The following is a description of a gene set: Mouse Gene Set: PPARGC1A_TARGET_GENES species: Mus musculus Genes containing one or more binding sites for (Ppargc1a) in their promoter regions (TSS -1000,+100 bp) as identified by GTRD version 20.06 ChIP-seq harmonization. from publication Yevshin I, Sharipov R, Kolmykov S, Kondrakhin Y, Kolpakov F (PMID 30445619), and this is the list of marker genes: Ccdc71, Schip1, Rtn4rl1, Pigo, Prkacb (NCBI Gene Id 18749), Gm11476, Akr1b7, Gtf3c3, Ago4, Gm24201, Taco1, Akap1, Spaca3, Commd1, Rpl3l, Gm28505, Snora26, Lrrc2, Tars2, Cerk, Gm22524, Prkcz, Adprm, Il23a, Dapk2, 5330439K02Rik, Prss23, Senp1, Tbcel, Or4c10b, Tmem184a, Ube3a, Rrp15 (ribosomal RNA processing 15 homolog), Gm26005, Mir6971, Rbpms2, Hmgxb4, Mrpl19, Caprin1, Lsm8 (NCBI Gene Id 76522), Snord3b-ps2, Gm26111 (predicted gene, 26111), Iscu, Rbm39, Phf20, Gm26159, Snord104, Des, Col27a1, Emc7, Eif3i, Gm13427, Mmp24, Gm23434, Cmc4, Sat1, Fam133b, Mitf, Adprhl1, Gpr107, Samhd1, Hspa8, Mir1903, Cox17 (cytochrome c oxidase assembly protein 17, copper chaperone), Rsad1, Or10q12, Nudcd3, Tfam, Psg19, Mccc1os, Fdx1, Igkv14-130 (immunoglobulin kappa variable 14-130), 1700122E12Rik, Herpud1, Gm15328, Gm23508, 9630013D21Rik, Gm6981, Taf2, Tusc2, A130014A01Rik, Baiap3, Lrrc36, Eno1, 9330136K24Rik, Phf5a, Pdgfc, Atad3a, Tmtc4, Mir452, Rps14, Mir5617, Plekhh3, Cpeb4, Pgls, Fam162a, Slc25a5, Ighv9-4, Tnnt3, Or8u9, Izumo3, Ap5b1, Fam78a, Sgk2, Spink14, Ppp1r11, Me3, Or7a39, Gm25794, Ndufa5, Tmem161b, Dhx38, Tmf1 (TATA element modulatory factor 1), Comt, Thsd4, Gm29815, Scn5a, Or6c3, Mt1, Cox7a1, C920021L13Rik, Dip2a, Tor3a, Pik3cb, Vmn1r-ps19, Gid4, Nrp1, Uqcc3, Banf1, Pou5f1, Zcchc13, Zcchc7, Ankrd2 (ankyrin repeat domain 2), Amelx, Tinagl1, Ccdc121, Vwa5a, Nampt, Ssr4, 4930554G24Rik, Ppp2r2d, Sra1, Slc1a1, Tesk2, Ky (NCBI Gene Id 28136), Glb1l2, Gnrhr, Adap2os, Vps37c, Smad4, Trappc11, Pnpla7, Gars1, Gm24958, Morc3, Ccdc117, Pdk1, Wdr62, Gm16892 (predicted gene, 16892), Eif3d, Hnrnph3, Apmap, Gatd3a, Gas7, Rxrb, Mettl25, Adss2, Eif2b4, Mtx2 (metaxin 2), Kpnb1, Atad3aos, Mia2, Ndufv3, Cept1, Trib1, Gprc5a, Pex2, Gm20732, Fam210a, Timm13, Oaz1, Fetub, Herpud2, A230065N10Rik, Hdhd5, Senp5, Ccdc174, Myt1, Fabp3, Kyat1, Dbt, 2310040G24Rik, Foxn3, Gm25767, Usp14, Hspe1, Phyh, 2310001K24Rik, Malat1, Or4c123, Ndufs2, Nisch, Gm25482, Atad5, 1700063D05Rik, Frg2f1, Dhx30, Itgb1bp2, Gm9946, Gtpbp4, Eef1a1, Bcs1l, Mfn2 (mitofusin 2), Tnip1, Mpc1, R3hdm2, A930007I19Rik, Gss, Ap1b1, Ppp2ca, Gpt, Zfp827, Gm4349, Ddx60 (DExD/H box helicase 60), Ndufb7 (NADH:ubiquinone oxidoreductase subunit B7), Cd82, Dmpk, Znrf1, Igkv2-95-1, Slc41a2, Gm25170, H2-M9, Mbnl3, Pabir1 (PP2A A alpha (PPP2R1A) and B55A (PPP2R2A) interacting phosphatase regulator 1), Dnm2, Atp6v0a1, Tmem218, AA465934, Dpysl3, Atp5f1c, Gm22652, Pan2, Ampd3, Aip, Mir7668, Gm9899, Ogdh, Pcolce, Caap1, Slc39a7, Gm14221, Fxyd2, Trim33, Ptf1a, Litaf, Apbb2, 2010003K11Rik, 4930555F03Rik, Cs, Glra4, Senp3, Gm13809, 4930461G14Rik, Abhd18, Syt7, Zfp1006, 4931440P22Rik, Adss1, Rdh13, Lypla1, Cog1, 3110031N09Rik, Arhgef18, Atxn2, Ciao3, Hdgfl1, 4732491K20Rik, Tsku, Pacsin2, Rab21, B230216N24Rik, Plxnd1 (plexin D1), Pdha2, Mir200b, Zfp36, Mir195b, Gm15340, Psma6, Ankrd13a, 1700007J10Rik, Echs1, Capns1, A230020J21Rik, Abcb7, Slc2a4, Gm16378, Myh2, Maip1, Itsn1, Stx6, Klk1b22, Phyhipl, Marchf7, Pacsin3, Mapk8ip3, Gigyf1, Myo1c (myosin IC), Il15ra, Mageb18, Ibtk, Gpn3, Gm8107, a (NCBI Gene Id 50518), Sacm1l, Zmpste24, Ip6k3, Tmem150a, Ezh1, Zmynd8, Ndufb8, Gm8666, Rreb1, Uck2, Clk4, Fancc, Mcm10, Nr0b2, Igsf8, Rrm2, Mad2l1, Sys1, Slc20a1, Sema3b, Zfp286os, Tprn, Ermn, Rpl41, A430078I02Rik, Yju2b, Clec2d, Thrap3, Myl4, Tmem79, Cfap418, Pik3r1, Grsf1, Slc25a35, Tsc22d3, 1700003H04Rik, Tdrd9, Gna11, Uqcrc2, Ddt, Gm13719, Alkbh7, Gar1, Zbtb11os1, Aard, Git2 (NCBI Gene Id 80654), Polr2e, Wnt5b, Stard10, Gm27021, Rnu12, Ap5m1, Or5d45, Ttc7b, Ndufa9, Psmd13, Uck1, Pigc, Taf3, Ankrd40, Rptor, Prex1, Gm7134, Gm32736, Mrps27, Mgme1, Gm37435, Cnot9 (CCR4-NOT transcription complex, subunit 9), Gm3716, Galt (NCBI Gene Id 14430), Evc (NCBI Gene Id 59056), Zfp365, Phc3, Klhl41, Stard7, Nol4l, Cachd1, Rmdn1, Scn1b, Crybg2, Traf3ip2, Tnrc6c, Pidd1 (NCBI Gene Id 80596), Pttg1ip, Snora81, Rusc2, Abca4, Or7c74, Slc16a1, Aldh1l2, Gmnn, Perm1 (PPARGC1 and ESRR induced regulator, muscle 1), Smg6, Zdhhc17, Impa2, Chtf8, Got1, Adck1, Spry2, Atp5me, Fry, Slc9a8, Rhbdf2, Sirt6, 2210414B05Rik, Gm12010, Pip4k2b, Vmn1r-ps8, Ighv1-11, Csn1s1, Timm10, Mtor, Bnc2, Akap8, Usp1, Nae1, Tnni1, Ubc, Ptpro, Zfp706, Mir3075, Ctdspl2, Sox5os4, Ccdc68, Odr4, Wdpcp, Cep104 (centrosomal protein 104), Emc4, Lrfn5, Tfr2, Crygs, Hs6st1, 1700010L04Rik, Gm13415, Iqcd, Hnf4g (NCBI Gene Id 30942), Mir6389, Tns3, Trp53rkb, 1700010I02Rik, Prss46, Smarcb1, Tmem43, Dedd2, Chrna1, Mir802, Pex12, Glra1, Gpr3, Parp11, Glis3, Pcdha8, Nmnat1, Gm26671, Zdhhc7, Gm40414 (NCBI Gene Id 105244886), Eif3l (NCBI Gene Id 68333), Pdcl3, Nucks1 (NCBI Gene Id 98415), Eef1akmt1 (EEF1A alpha lysine methyltransferase 1), Hdac11, Ciz1, Mtx3, Gm22339, Muc20, Hdhd3, Vegfa, Pcyox1, Frmd8os, Syngr2, Tmem62, Gm15543, Rimoc1, Ndufs4, Sbsn, Ndufv1, Gapdh, Lrp2, Hipk2, Lztr1, Nfic, Cfap69, 4732440D04Rik, Lrig1, Pld1, Rttn, Cela3b, Tomm5, Stard9, Utp4, Tspan9, Ndufa4, Ncbp1, Dok7, Egfl8, Mrpl1, Palld, Gm53055, Bbs10, Hnrnpf, Hapstr1, Zfp850, Prss22, Poc1a, Card10, Gcc2 (GRIP and coiled-coil domain containing 2), Zfpm1, Zfp442, Cenpu, Stub1, Mrln, Ptrh2, Isy1, Ttc39b, Il33, Pls3, Ift57, Marchf8, Irf3, Tonsl, Cers5, Arl5b, 1700084C06Rik, 4930507D10Rik, Or2t35, Ect2, Ndufb2, Six1, 6430573P05Rik, Gm12826, Rasl10b, D430001F17Rik, H13, Gm13836, Slc25a34, Dynll2, Mindy3, Psmb11, Pax4, Flad1, Capn15, Gm16191, Hk1os, Slc16a2, Gm14472, Mcph1, Card6, Spata33, Trdmt1, Mtpap (mitochondrial poly(A) polymerase), Gm24593, Letmd1, Rny1, Tmc8, Uqcc1, Kcnj16, Tmc6, Sh3bgr, Txn2, Osbpl1a, Slc36a1, Tfrc, Lcn2, Sumf2, 2700097O09Rik, Mdc1 (NCBI Gene Id 240087, mediator of DNA damage checkpoint 1), Abhd13, Synpo, Bag3, Mrpl39, Gm10382 (NCBI Gene Id 639281), Mospd3, Naa20, Plk2, Mecomos, 4930432B10Rik, Nat8f4, Plet1os, Atp1a1, Ptgr2, Ptprv, Slc25a26 (solute carrier family 25 (mitochondrial carrier, phosphate carrier), member 26), Met, Dtd1, Ncoa6, Mir7b, Atp5po, Oxct1as, Gm7285, Kdm1a, Flii, Zfp382, Ssbp2, Mir883b, Akain1, Gpr68, Crip2, Mideas, Aco2 (aconitase 2, mitochondrial), Atg3 (autophagy related 3), Gm25896, Npm2, Dhx8, Carmil1, Tnfrsf9, Afg1l, Cpt1b, Tmem130, Adamts3, Smim8, Gapvd1, Resf1, Hmgb1 (NCBI Gene Id 15289), Crkl, Krt4, Pla2r1, Mpv17l2, Nelfb, Mrps15, Zcchc8, 2310061I04Rik, Tor1aip1, 1700011B04Rik, Dffb, Ppp2r5e, Oog3, Riok3, Zfp202, Piezo1, Gfm1, Slc25a29, Emc8, Klhl30, Gm13489, Ccdc12, Mrps18b (NCBI Gene Id 96968), Rtkn, St7l, Ank1, Neat1, Zfp142, Stat3, Pafah2, Naa35, Pimreg, Zkscan14, Cobll1, Pold3, Gm26513 (predicted gene, 26513), Gm14170, Stimate, Mir133a-2, Otop1, Ifi27, Lig4, Cdc73, Pdlim4, Casq2, Snhg8, Gm10524, Knop1, Btbd3, Tpr, Dlgap4 (DLG associated protein 4), Ak1, Eogt, Mprip, Pgap4, Guca2a, Fbxo3, 1110015O18Rik, Kin, Arhgap22, Sp1 (trans-acting transcription factor 1), Gpr158, Afg2a, Tbc1d32 (NCBI Gene Id 544696), Slc25a4, Rpap3, Snora24, Sp3, Pipox, Gm26022, Bcl2l15, Ccdc96, Opa1 (NCBI Gene Id 74143), Eif3h, Cyb5r4, Rnf123, Fastkd1, Mtg1, Midn, Srgap3, Tcf4, Gm49405, Dhx37, Nfyc, Fam13a, Celf6, Tspan3, Gimap6, Cnnm3, Nrbf2, Cyp19a1, Etohd2, Lzts2, Evi2a, 6030471H07Rik, Stxbp4, Fbxo5, A030012G06Rik, Slc10a3, Frmpd1, Zfyve16, 2700049A03Rik, Gm25726 (NCBI Gene Id 115486352), Pitpna, Dst, Ubqln4, Sectm1b, Car2, Aspa, Prss3b, Tfeb, Ptbp3, Zfp768, Tpd52l2, Ttc22, 9330111N05Rik, Ube2i, H2ac21, Bub1b (BUB1B, mitotic checkpoint serine/threonine kinase), Acer2, Rnaseh2a, Eps15l1, Mettl23, Eif4ebp3, Ccnt2, Srpra, Ndel1, 1700063H06Rik, Sco1, Kyat3, Guf1, Gemin5, Parp2, Pop1 (processing of precursor 1, ribonuclease P/MRP family, (S. cerevisiae)), Smok2b, Kntc1, Cfap91, Rpl36, Art1, Sema4b, Smim13, Ccne1, Gm10766, Gm9824, Il1a, B230369F24Rik, Tmem70, Lgals1, Zfp335, Styx, Gm24289, Mrps21, Ppp1cb, Klk6, Zfp383, Hagh, Ndufaf4, Ttc19, Steep1, Tbx15 (T-box 15), Gm26922, Cdt1, Mir7044, Dennd4b, Srsf4, BB019430, Slmap (NCBI Gene Id 83997), Trim55, Txnrd2, Plcxd2, Gm15395, B930094E09Rik, Tpra1, Dnajc1, Wwox, Gm24440, Slc25a33, Gm26885, Mir190b, Ogt, Fahd1, Ermp1, Gm25630, Stk11, 9530003O04Rik, Gm7833 (predicted gene 7833), Fhad1, Eif4e2, Tomm40l, Gm14921, Gm6283, Bicc1, Gpm6a, Trmt61a, Gm4419, Myod1, Ehd4, Chka, Aurkb, Gm14802, Lyve1, Gm12860, Tpm3, Tpd52, Atp5mg, Or4c3, Foxj3, Mir6359, Alkbh6, Tuba1c, Zfp612, Ewsr1, Asb15, Ap5s1, Nme1, Ckmt1, Mrpl33, 5330439B14Rik, Cltc, Tuba1a, Slc12a5, Tbc1d25, Plekhg3, Cbfa2t2, Tet2, Kbtbd4, Rap1gds1, Cflar, Stxbp5, Ap2b1, Retreg1, Gm6407, Ccdc6, Fam53b, Rnf11, DQ267100, Tm6sf2, Pcsk4, Gabpa, Tbrg4, Sirpd, Etfa, Rilp, Grn, Vdac1, Tesl1, Pard3, 2310058D17Rik, Rpl27a, Nck1, Rfc4, Tmem134, Vegfb, Tmco6, Snord59a, Ppp2r2c, Acad11, Gm16279, Gm30382, Ppm1l, Tdp2, Sqor, Acot13, Hspb7, Tefm, Acot5 (NCBI Gene Id 217698), Trmt2b, Tomm70a, Fbxo30, Tdrd3, Gm23463, Psg16, Arap2, Spata17, Katnip, 1600014C10Rik (NCBI Gene Id 72244), Gm23625, Fars2, Ankrd9, Evi5, Vwa8, Meis2, Rbm17, Pmf1, Chd7, Mkln1os, Slc4a3, Gm12230, Gm25010, Gm13679, Wnk1, Tcirg1, Nupr1, Ndufs8, Gm10516, Oxa1l, Vmn1r234, Cenpe, Ighv1-12, Prdx2, Chchd3, Cemip2 (cell migration inducing hyaluronidase 2), Slc7a4, Irgq (NCBI Gene Id 210146), Sgms1, Tug1, Gm14716, Wdr25, 4930524O07Rik, D730003I15Rik, Crlf3, Cdc14b, Shld2, BC051076, Ankle2, Tlcd1, Gm6542, Gdf15, Gpcpd1, Fam181a, Strip1, Srrm4, Ss18l2, Gm4366, Gm29346, Gde1, 1700011L22Rik, Anxa6, Slc20a2, Ccser2, Uqcrq, Yju2, Sh3bp5, Gpbp1l1, Gm14210, Adm, Lmbrd1, Thumpd3, Gm2824, Car13, Slc33a1, Rnmt, 2810408A11Rik, Calr, Hsp90b1 (heat shock protein 90, beta (Grp94), member 1), Pnpla2, P2rx4, Mir5135, Plin2, Gm10863, Utp25, Zfp248, 2900079G21Rik, Adamts14 (ADAM metallopeptidase with thrombospondin type 1 motif 14), Gm26165, Foxf2, Oosp3, Inpp4b, Gm26596, Prop1, Tpk1, Aar2, Med26, Aaas, Plscr2, Gm8177, Slc38a1, Gm28513, Borcs6, Gm29214, Map2k2, Tmem63c, 2810405F17Rik, Gm5513, A230072E10Rik, Slc6a19, Nelfe, Ndufs7, Srxn1, Uba5, Coro7, Rbms1, Atp5f1a, Mfn1, Bcar3, Fam234b, 2900072N19Rik, Tex50, Cacna1g, Wdr36, Tpm2, Ubash3a (ubiquitin associated and SH3 domain containing, A), Neu1, Dna2, Klhl21 (kelch-like 21), Or51a24, Gssos1, Gm25711, Gadd45b, Ldhb, Ythdf3, Cdk15, Taf5l, 1810041H14Rik, 1110002J07Rik, Grwd1, C920006O11Rik, Or4c127, Spaca4, Sucla2, Lrrc41, Gm2574, Hoxa3, Emp1, Gm15179, Herc1, Slc35a5, Manba, Drg2, Gm15782, Ajuba, Timm9, Map3k4, Micos10, Acaca, Ugt2b34, Got2, Gm7504, Cdc42bpg, Atp6ap2, Efr3a (EFR3 homolog A), Ecpas, Clasp1, Get1, Lsp1, Galc, 5430402O13Rik, Spag1, Alas1, Rin1, Etfbkmt, Pygb, Samm50, Orai1 (ORAI calcium release-activated calcium modulator 1), Commd5, Ap1g1, Myc, Calu, Ttll11, Golga1, Cul4b, Tut4, Abra, Srek1ip1, Qrsl1, Polr3h, Iho1, Il31ra, Uqcc6, 5031425E22Rik, Mir378c, Ctnna2, Lbh, Rps6ka3, Slc4a2, Gm24677, Msantd7, Or11g26, Tns1, Trp53inp2, Fam8a1, Tle6, Hnrnph1, P2ry2, Spp1, Bsg, Mitd1, Gm17808, Selenom, Cp, Cluh, Ldlrap1, Zfp62, Or4a71, Uqcrc1, Gm29481, Gtf3c6, Zfp385b, Med16, Mir339, Shox2, Tchhl1, Asap1, Rdh9, Ptpa, Jakmip1, Dipk2a, Lzic, Gm25637, 4930579G24Rik, Manf, Tpst1, Cdk13, Oplah, Smad3, Cox4i1, Cmpk1, Kif1b, Hspd1, Rnf14, Gm5874, Casp16, Tex53, Zfp691, Plpp2, Gm14103, Pgm2 (NCBI Gene Id 66681), Gm15500, D17H6S53E, Muc3a, Dhx34, 2010010A06Rik, Cox6b1, Sirt3, Tceanc, Ganc, Gm13877, Uqcrfs1, Tkt, Slco1a4, Myoz2, Nap1l4, Zfp526, Snap29, Ptprc, Cox5a, Or14c40, Gm10373, Sgsm1, Uspl1, Zfp672, Ap4e1, Slc38a10, Magoh, Rsrp1, Oxct1, Calr3, Nek4, Abl1, 2310016D03Rik, Msl3, Nlrc3, Faddos, 4930558K02Rik, Med28, Ppp1r10, Zfr2, Gm8141, Gm23609, Tdg-ps2, Irx3os, A930003A15Rik, Kcnip4, Cdc42ep2, Ankrd23, Pigt, Gm24494, Iqck, 2810001G20Rik, St6galnac6, Copb2 (COPI coat complex subunit beta 2), Dph5, Ccdc50-ps, Macroh2a1, Cep85, Tas2r114, Bcl2l12, Mir6236, Ctso, Eif2b2, Gm28645, Prcc, Ndufb10, Gm13017, Rps15a-ps7, 3425401B19Rik, Igkv13-78-1, Psmc3ip, Vmn1r232, Slc22a5, Cux2, Kansl3, Mgat2, Myhas, Nosip, Gm9905, Gm8816, Pop4, Gm26766, Ccdc62, Wdr11, A930005H10Rik, Poldip3, 1600014C23Rik (RIKEN cDNA 1600014C23 gene), Cwf19l1, Rrn3, Gm10231, Zscan2, Lrrc59, Mrpl41, Il1rapl1, Eif1ad, Ccdc127, Utrn, Tmem186, Vapa, Rbbp6, Tyw5, Nit2, Cped1, Prodh, Gm11996, Dgcr8, Abhd10, Gm5776, Ipcef1, Plec, Gm7346, Mms19, Slk, Zc3h7a, Tcf3, Tbkbp1, Mrpl20, Zfr, Esrp1, Zfp462, L2hgdh, Ncor2, Klk1b21, Tra2b, Rgs17, Gm13326, Zbtb20, Ubqln2 (ubiquilin 2), Gm5420, Shb (NCBI Gene Id 230126), Slc29a1, Gria2, Prl8a8, Exoc5, Hnrnpl, Shmt1, Ttc41, 1700023G09Rik, Hspa5, Ccnjl, Gm16080, Naca, Ffar4, Nceh1, Trim41, Ago3, Numb, Gm5600, Lin9, Gm22977, Ndufs3, Eif4a2, Xpnpep1, Atp5f1b, Strbp, Atp5pf, Dclre1a, Zfp629 (NCBI Gene Id 320683), 4930505O20Rik, Mir3071, Myh13, Kctd5, Dcbld2, Septin6, Myo1b, Slc25a16, Usp37, Tmem250, Zfyve9, Mir6347, Slc30a7, Pde10a, Igbp1b, Slc35f4, Abcb8, Rhbg, Mir345, Irag2, Arhgef2, Banp (BTG3 associated nuclear protein), Zfp622, Clcn7, Sec24a, Wnt7b, 4930562A09Rik, Trap1, Desi2, Ppp1r27, Fzd5 (NCBI Gene Id 98335), Fscn1, Nexn, Ctss, Zmiz2 (NCBI Gene Id 97766), Ercc1, Slc6a6, Or3a15-ps1, Il17a, Dnajc15, Cab39, Cycs (cytochrome c, somatic), Cdnf, Kdm5a, 1700067P10Rik, Rap2c, Bin1, Tmc5, Mllt11, 1810034E14Rik, Urb2, Caprin2, Arid5a, Ttc23, Etl4, Dmac2, B930036N10Rik, Abcc8, Vmn1r212, Cers2 (NCBI Gene Id 99568), Cenpj, Swi5, Abca12, Fth1 (NCBI Gene Id 14319), Snord45b, Stambpl1, Usp3, 1700024G13Rik (RIKEN cDNA 1700024G13 gene), Ndufab1, Sergef, Gm22358, Tstd2, Fsd2, Traj20, Dnai7, Mtfp1, Gm19035, Aldh3b2, Rsph3a, 4933425M03Rik, Gm30270, Rb1cc1, Pradc1, Stradb, Wars2, Git1, Nup54, Gm14925, A230107N01Rik, Tmem87a, Nudt5, Zmat5 (zinc finger, matrin type 5), Adamtsl5, Ckmt2, Ncbp2as2, Rpl9-ps5, Mir8102, Serpinb9c, Gm19058, Rabggtb, Cep350, Atf1 (activating transcription factor 1), Wars1, Dnajc10, Atp5mc3, Gm5459, Calcrl, Gm12201, Speg, Psma1, Spink4, Rsbn1l, AA986860, Rxfp1, Brms1, Tcaf1, St3gal3, Or10g1, Atg7, Zfp148, Coq5, Crocc, Or14j9, Atg5lrt, Gpr35, Mir8120, Gm10561, Ung, Fem1b, Nmrk2, Dot1l, Syne2, Scyl1, Hycc2, Wdr77, Cib4, A430105J06Rik, 1700063K16Rik (RIKEN cDNA 1700063K16 gene), Zcchc17, Bcl2l1, Kidins220, Mm2pr (macrophage M2 polarization regulator), Srrm3, Txnrd1, Tbc1d9b, Scfd2, Atg5, Septin14, Fbxo11, Upp1, St6gal1, Spg7, Atp5pb, Or7g33, Smurf1, Podn, Mkln1 (NCBI Gene Id 319270), Gdf9, Bmf, Dnajb5, Arfip1 (ADP-ribosylation factor interacting protein 1), Krtap28-10, 1700024B18Rik, Nktr, Tm7sf3, Trpm8, Gal3st1, Ccnd2, Cand1, Ube3d, Ndufa10, Gm10156, Fam98b, Atf2, Dedd, Golga5, Mir1960 (microRNA 1960), Fra10ac1, Bcl2, Rac1, Ddx56, Ywhaq, Slco4a1, Lyrm4, Tmem11, C4bp, 9130017K11Rik, Sec24b, Snx17, 1700007L15Rik, B4galt7, Zcchc4, Dhx32, Gm22858, Ppp1r16a (NCBI Gene Id 98002), Ift80, Pi4kb, Slc6a19os, Ighv5-10, Gm4430, Fosl2, Ptcd2, Zfp27, Tead1, Tatdn1, Wdr17, Ppp3ca, Snord45c, 3830432H09Rik, Gm20522, Ncor1, Dap3, Uckl1os, Smyd2, Birc6, Pla2g6 (phospholipase A2, group VI), Zfp532, Ythdc2, 9930111H07Rik, Pyy, Ric3, Arid4a, Exoc3, Rbm20, Gm30238, 1700047K16Rik, Slc19a2, Neurl4, Krit1, Pde4d, Pacrg, Hpdl, Lgmn, Trim63, Gm24119, Aars2, Amacr, Timm21, Gm15422 (predicted gene 15422), Plekha8, Gh, Mbtps2, Park7, Cirbp, Atp4b, Cdkl3, Slc35a4, Dlat, Ncbp2, Nfatc2, Pmm2, Tnpo3, Rbck1, Repin1, Bach2os (NCBI Gene Id 414068), Cdk5, Idh3b, Clec4e, 1700022N22Rik, Gtf2ird1, Slc16a11, Clcnkb, Slc22a4, Gm20652, Gabarapl1, Mars1, Uqcr10, Ppp2r3d (NCBI Gene Id 626662), Ttc8, Nfe2l1, Twf2, Setdb1, Tnnc1, Tmem234, Srl, D930019O06Rik, Tmbim1, Cox6c, Clstn1, Cda, Kmt5a, Agtpbp1, Lrba, Pigw, Aebp2, Atp6v1b2, Fam110b, Tmem160, Pcdhb20, Tmco4, Gm28609, Tmt1b, Mir6961, Fam161b, Med23, Rtn4ip1, Ddit3, Asns, Tm4sf20, Cfh, Cenpa, Rft1, Trak2 (trafficking protein, kinesin binding 2), Esrra, Gm28650, Eif4enif1, Lrp2bp, Map2k3, Ubl4a, Xirp1, Gm13787, Klhl32, Stk4, Acadm, Pex3, Lrrc8e, Amy1, Abtb3, Cep131, Atp1b1, Tmem120b, Ndufb5, Chchd2, Samd4, Mbnl1, Atp5mc2, Ubac2, Lims1, Mbd6, Mphosph8, Gm33651, Nop14, Cep135, Pkib, Atp5mc1, Spata9, Nav1, Gm14441 (predicted gene 14441), Alkbh3os1, Tln1, Gpi1, B230206L02Rik, Inpp5j, Gm26427, Gm10570, Lamtor2, Fbp2, Skic2, Rev1, U2surp, Usp43, Card19, Raly, Ndufc2, Col7a1, Gm20186, Lasp1, Pitpnm3, Mpi, Gnas, Fnip2, Steap2, Prdx1, Mettl9, Fcna, Fndc3a, Gpr146, Gm8093, Map1a, Sptlc2, Rian, Zfp236, Lnx1 (NCBI Gene Id 16924), Bcorl1, Tmem97, Gpatch2, Tnni3, Acsf3, Greb1l, Ghitm, Sigmar1, Larp1b, Ptpn5, Gm4982, Slc25a39, Scrt1, 4930448D08Rik, C230029F24Rik, BC025920, Kpna3, Mpzl3, Coq10b, Faf1, Hpn, Gm20621, Sspnos, Oxnad1, Gm25139, Epha2, Diaph1, Dhrs9, Hand2os1, Alkbh8, Glud1, Fuz, Igkv8-22 (immunoglobulin kappa chain variable 8-22), Pdss1, Cacng8, Ano1, Alkbh3, Ube2o, Txnl4b, Jam2, Mcur1, Mecom, Snx3, Gm26447, Tspan13, Dph3, Sphk1, Kmt2e, Rbm10, Junos, Tab1, Mob4, Emx2, Bltp1, Nabp1, Slc25a3, Mapk1ip1, Bod1l, Klhl22, Dusp1, Jmjd6, Or4d11, Parl, Tsen54, Gm8817, Gas2l1, Mrpl38, Cox20, Cdc42se1, Vmp1, Gm27252, Cdc123 (cell division cycle 123), Mrpl30, Lonrf1, Phf14, Slc23a2